The following is a description of a gene set: part of: Fatty acid metabolism studied in species Mus musculus Reactome Pathway: alpha-linolenic (omega3) and linoleic (omega6) acid metabolism electronically inferred by orthology from the curated human pathway This event has been computationally inferred from an event that has been demonstrated in another species.<p>The inference is based on the homology mapping from PANTHER. Briefly, reactions for which all involved PhysicalEntities (in input, output and catalyst) have a mapped orthologue/paralogue (for complexes at least 75% of components must have a mapping) are inferred to the other species., and this is the list of marker genes: Elovl5, Elovl3, Abcd1, Hsd17b4, Acaa1b, Elovl2, Acot8